The following is a description of a gene set: studied in species Homo sapiens Signaling by FGFR1 Human Gene Set: REACTOME_SIGNALING_BY_FGFR1, and this is the list of marker genes: FGF8, FGF2, FRS3, HRAS, FLRT1, SPRED1, FGF17, FGFR1, GAB1, MAPK1, RPS27A, FGF6, ANOS1, KL, FLRT2, GRB2, NRAS, FGF1, UBC, KRAS, MKNK1, SOS1, FLRT3, FGF20, FGF4, SPRED2, PPP2CB, FGF22, TGFBR3, BRAF, PPP2R1A, SHC1 (NCBI Gene Id 6464), SRC, MAPK3, PLCG1, PPP2CA, FGF5, PIK3CA, FRS2, GIPC1, FGFRL1, PTPN11, FGF18, CBL, SPRY2, UBB, FGF3, FGF9, FGF10, FGF23, UBA52, PIK3R1